The following is a description of a gene set: Any process that modulates the frequency, rate or extent of gene expression by which developmental control passes from the maternal genome to the zygotic genome. Mouse Gene Set: GOBP_MATERNAL_TO_ZYGOTIC_TRANSITION_OF_GENE_EXPRESSION species: Mus musculus, and this is the list of marker genes: Btg4, Kmt2b, Pabpn1l, Nr5a2, Obox5, Obox7, Obox1, Obox3, Lsm14b